Given this list of marker genes DLG1, TMEM38B, KCNF1, KCNMB3, PKD2, KCNA1, KCNK12, STK39, SLC12A8, KCNIP1, KCNJ13, CAV1, KCNJ8, SLC9C2, KCNQ3, KCNG4, ARPP19, SLC24A4, KCNK1, AMIGO1, KCNE2, KCNMB4, KCND2, KCNA7, KCNH7, KCNAB2, SGK1, SCN2B, KCNJ6, KCNK17, HCN4, SLC24A3, KCNJ12, KCNK13, SLC12A5, KCNE3, KCNA10, KCNIP3, KCNH2, KCNAB1, ADRB2, ATP12A, TMEM175, KCNH1, SGK2, SNAP25, KCNV2, KCNJ18, SLC5A3, SLC9C1, KCNE5, SLC9A6, FHL1, SLC9A3, KCNH5, KCNC4, KCNN4, P2RX7, KCNQ1, GRIK5, KCNB1, SLC12A4, KCNQ2, KCNJ15, KCNN2, KCNJ10, SLC9A1, KCNT1, GRIK1, MCOLN3, KCNK4, SLC12A1, WWP2, SLC24A2, KCNK5 (NCBI Gene Id 8645), KCNA4, KCNK10, LRRC55, KCNT2, KCNC3, ATP1A4, SLC24A1, YWHAE, C8orf44-SGK3, KCNJ1, KCNG2, HCN3, DPP6, ATP4A, SLC9A4 (solute carrier family 9 member A4), KCND1, TMEM87A, KCNA5, KCNH4, KCNS2, KCNG3, KCNS1, KCNS3, KCNC1, DRD4, DRD2, NEDD4, AKAP9, CAV3, SLC9A2, TMEM38A, MCOLN1, SLC12A6, SLC12A9, KCNQ4, HCN2, GRIK2, ATP1A2, ATP1B1, HCN1, KCNN1, SGK3, KCNK16, ANK2, GRIK3, SLC24A5, KCNE4, KCNJ9, KCNJ11, KCNJ3, KCNN3, CCT8L2, SLC12A2, ABCC8, KCNIP2, KCNK2, OXSR1, TMCO3, KCNA3, SLC17A6, CHP1, KCNJ4, ABCC9, KCNH8, KCNMB2, SUMO1, KCNAB3, LRRC26, KCNG1, CCDC51, SLC9A8, GRIK4, KCNK15, LRRC52, SLC12A3, KCNK9, DPP10, AQP1, SLC9A5, KCNQ5, KCNK18, SLC17A7, KCNE1, KCNC2, KCNH3, ENSA, KCNU1, RASA1, KCNJ2, KCNB2, KCNH6, TRPM5, KCNMA1, NEDD4L, ATP4B, KCNK6, SLC9A9, KCNJ16, KCNJ5, SLC12A7, FLNA, KCNK7, KCNIP4, KCNA6, KCND3, KCNMB1, ATP1A3, KCNJ14, KCNA2, SLC9A7, ATP1A1, LRRC38, KCNK3, KCNV1 (potassium voltage-gated channel modifier subfamily V member 1), PKD2L1, AKT1, here is a description of the gene set: Enables the transfer of potassium ions (K+) from one side of a membrane to the other. species: Homo sapiens Human Gene Set: GOMF_POTASSIUM_ION_TRANSMEMBRANE_TRANSPORTER_ACTIVITY